The following is a description of a gene set: species: Homo sapiens Any process that modulates the rate, frequency, or extent of a change in state or activity of a cell (in terms of movement, secretion, enzyme production, gene expression, etc.) as a result of a growth factor stimulus. Human Gene Set: GOBP_REGULATION_OF_CELLULAR_RESPONSE_TO_GROWTH_FACTOR_STIMULUS, and this is the list of marker genes: PROX1, DLL1, IL1B, CYFIP2, RBPMS2, MIR361, PDCD6, ARID4B, LOX (lysyl oxidase), AGT, MIR30B, LRRC32, CTNNB1, CASK, CREBBP, GREM2, FOXD1 (forkhead box D1), MIR424, FGF2, FLCN, PBLD, SMAD3, CHRDL2, TP53 (NCBI Gene Id 7157), ACVRL1, DOK5, VEGFC, CFLAR, ASPN, PMEPA1, MIR302B, MIR10B, FGFBP3, RNF111, ITGB1, ADAMTS12, FBN2 (NCBI Gene Id 877), HES1, SMAD2, VWC2, BCL9, SMURF2, SPRY2, CDKN2B, NGLY1, NBL1, OTX2, JCAD, CDKN1C, HDAC2, PRDM16, PIN1 (NCBI Gene Id 5300), FSTL1, CD63, ADGRA2, MIR329-1, CTDSPL2, NRROS, LRIT3, MIR342, SHISA2, MIRLET7F1, THBS1, DKK3, ROBO1 (roundabout guidance receptor 1), PRMT1, ABL1, MMRN1, ARK2C, SMAD5-AS1, USP15, IL4, ADAM17, MIR125B1 (microRNA 125b-1), WNT4, PDPK1, CDH5, PPARG, MIR885, MIR19B1, XBP1, NOTCH2, PALS1, PIK3CB, MIR498, HTRA3, MIR1-1, MIR204, MIR195, PELO, MIR376C, CIDEA, WNT5A, TMEM53, MIR503, GATA4, GPR155, FERMT1, ZBTB7A, LTBP1, APLN, SKOR2, MIR16-1 (NCBI Gene Id 406950), DLX1, NPNT, NRXN1, MIR200C, CER1, FZD1, ADISSP, SMAD7, SINHCAF, OVOL2, BMP4, MIR17, SMURF1, ADAMTSL2, MIR142, WFIKKN2, TOB1, SFRP1, SAP30, ITGB3, DAND5, KCP, SMOC2, CRIM1, PPP2R5B, MIR210, ZNF423, SKIL, UBE2D3, GRB10, IL17F, CHRD, STK11, VEPH1, VWC2L, TBX20, SOX11, SIRT1, BMPER, MMRN2, EID2, MIR302C, TFAP2B (NCBI Gene Id 7021), ADGRG1, LTBP4, WASF1, SPRY4, PRDM14, MICOS10-NBL1, MIR101-1, IL12A, TWSG1, MECOM, ARID4A, MIR1224, SULF2, SFRP2, SKI, NRP1, GIPC1, FGF18, BRMS1L, LRG1, NOG, HSPA1A, GPC1, LDLRAD4, SIN3A, KDR (NCBI Gene Id 3791), MIR93, ING2, SOSTDC1, SFRP4, CITED1, GATA3, DKK1, GOT1 (NCBI Gene Id 2805), FKBP8, SLC2A10, OFD1, VASN, NREP, EMILIN1, DMD, TGFBR3L, GDF15, GDF3, FOLR1, MIR20A, UBE2O, NGFR, HRG, ERFE, SNW1, CAV1, NUMA1, PRKD2, MIRLET7B, SPRY3, SDCBP, SORL1, HSP90AB1, HIF1AN, ITGA5, SPRED1, DSTYK, MIR27B, HIPK2, HSPA5, MIR146A, CAV3, TET1, EPN2, SOST, FGF10, GPC3, CD109, XIAP, CITED2, VTN, PPARA, RBBP7, MIR19A, FSTL3, MIR26A1, ZDHHC17, ZEB2, BMP2, MIR199A1, MIR490, MIR564, ITGA3, CYFIP1, PPM1A, SMAD4, LRP2, MYOCD, ANGPT1, FKBP1C, MIR573, LATS1, ILK, TSC22D1, FGF1, CRB2, PCSK6, SNX6, MIR18A, RBBP4, CHRDL1, LATS2, SAP130, MIR497, FGFBP1, NKX2-1, MIR199B, MIRLET7A1 (microRNA let-7a-1), HES5, ATP2B4, ZNF703, MIR21, MIR181A2, SAP30L, MEN1, RASL11B, MIR98, CADM4, SEMA6A, MT3, OGT, TMEM204, SULF1, ENG, VEGFA, MTMR4, MSX1, SMAD6, GDF2, TGFBR3, CXCL13, FAM20C, ING1, SNX25, MIR323A, MIR520C, AXIN1, PTP4A3, HIF1A, CAV2, ZEB1, BAMBI, FSTL4, CDH3, EP300, MIR15A, GDF5, HGS, SPRED3, MIR372, ONECUT2, HTRA1, MSX2, HOXA13, NPTN, PEG10, FST, FGF4, MIR214, ONECUT1, STRAP, FBXL15, HHEX, TNXB, WFIKKN1, TGFB1I1, STUB1, LEMD3, GLG1, NEO1, BRMS1, SUDS3, UBE2D1, FSTL5, FBN1, PRKCB, MIRLET7G, RBPJ, MIR100, FUZ, TRIM33, CREB3L1, MIR29B1, GREM1, CHST11, HJV, SCUBE3, MIR140, ELAPOR2, TNFAIP6, DCN, ADAMTS3, VEGFB, NEDD4, TMPRSS6, RGMA, MIR9-1, MIR145, CILP, BCL9L, WNT1, SLIT2, CCN1, ZNF451, CCBE1, SKOR1, PTPN1, ARNT, SPRED2, SPRY1, TSPAN32 (NCBI Gene Id 10077), IL12B, NR2F2, HHIP, NOTCH1, MIR296, FZD4, TMEM108, FGF9, MIR149, HTRA4, FAM89B, SPART, MIR15B, FKBP1A, RUNX2, MIR373, MIR106A, IL17RD, HDAC1, DAB2IP, ITGA8, FGF16, MIR10A, INTS9, AGTR2